The following is a description of a gene set: Any process that increases the rate, frequency, or extent of cartilage development, the process whose specific outcome is the progression of the cartilage over time, from its formation to the mature structure. Cartilage is a connective tissue dominated by extracellular matrix containing collagen type II and large amounts of proteoglycan, particularly chondroitin sulfate. Human Gene Set: GOBP_POSITIVE_REGULATION_OF_CARTILAGE_DEVELOPMENT species: Homo sapiens, and this is the list of marker genes: MUSTN1, HOXA11, RUNX2, ACVRL1, BMP4, MDK, GDF6, FGF18, GDF5, SOX6, SCX, GLI3, ZNF219, BMP6, BMP2, PKDCC, ZBTB16, SMAD7, POR, TAPT1, BMP10, SOX9, BMPR2, SMAD1, CCN1, LOXL2, WNT5A, PRKG2, BMPR1B (bone morphogenetic protein receptor type 1B), SOX5, BMP1, GDF2, SMAD3